Given this list of marker genes PPP4R3A, PPP4R3B, PRKAG1, PPARGC1A, PRKAG3, KAT2A, NNMT, PRKACA, PTPN2, MIR103A1, SIRT7, ARPP19, GCG, MIR107, PRKAG2, DGAT2, PPARA, DDB1 (NCBI Gene Id 1642), KAT2B, WDR5, SIRT1, CRY1 (cryptochrome circadian regulator 1), FOXO1, here is a description of the gene set: Any process that activates or increases the frequency, rate or extent of gluconeogenesis. species: Homo sapiens Human Gene Set: GOBP_POSITIVE_REGULATION_OF_GLUCONEOGENESIS